Given this list of marker genes MMD, BAZ2B, TCP11L1, AMMECR1L, FERMT1, DCAF8L1, IRF2BP2, RIC1, RBMS3, CHKA (NCBI Gene Id 1119), RNF38, CRYGN, DMXL2, TREM1, TEAD1, PCMTD1, CILK1, DMD (dystrophin), IVNS1ABP, FHL2 (NCBI Gene Id 2274), TEF, RNF135, BOD1, HIVEP3, UGP2, ZNF544, TMEM200A, SLC30A4, SLC12A5, IFIT2, ZNF586, TLCD4, MYO1B, PCOLCE2, GTF2H1, DCAF6, GAA, HOXD9, VPS26B, ROBO1, PDZD8, PFN2, PTPN14, SLC38A2, CTNNA3, LUZP1, KLHL14, PLGLB2, TMEM144, PDZD2, UNKL, SYT14, ZNF773, CEP85, CHD9, SPRED1, ROBO2, ZFHX3, PTAR1, FAM167B, DLG2, SELENOT, PLGLB1, ADAMTSL1, FANCI, AP1AR, SLC17A6, SGMS1 (sphingomyelin synthase 1), ASB5, SRPRA, CD46, FAM20C, KIF5B (kinesin family member 5B), BCAT2, REST, DNAJC30, YIPF4, GATA6, IKZF2 (NCBI Gene Id 51173), FAM240A, SH3PXD2A, SCUBE3, MATN3, GRHL1, PTPRO, UPF3B, PRR27, HERPUD2 (NCBI Gene Id 64224), P2RY14, ARB2A, NSMF, CHD2, TRAF3, HNF1B, THSD7B, DOCK5, CLOCK, TECPR2, DPP10, NOX4, B3GALNT2, CDK7, CREG2, CHST1, CDCA7L, FAM181B (NCBI Gene Id 283223), ZNF208, PAPPA, BAHCC1, GPR180, JOSD1, LYST, here is a description of the gene set: Human Gene Set: MIR7703 from publication Chen Y, Wang X (PMID 31504780) studied in species Homo sapiens Genes predicted to be targets of miRBase v22 microRNA hsa-miR-7703 in miRDB v6.0 with MirTarget v4 prediction scores > 80 (high confidence targets).